Given this list of marker genes Mtor, Chrnb2, Atp1a3, Npas4, Rptor, Ext1, Htt (NCBI Gene Id 319350), Atxn1, Chd8, Il1b, Dlg4, Brinp1, Tsc2, Ankrd11, Pianp, Nlgn2, En1, Bpifa1, Grpr, Drd1, Gad1, Nlgn4l, Grin1, Grid1, Septin5, Cln8, Cic, Vps13a, Oxtr, Gabrb3, Avpr1a, Shank2, Pcm1, Nfix, Cx3cr1, Ltf, Bpifa5, Brinp3, Kalrn, Dvl1, Dscam, Gng8, Ulk4, Cntnap2, Cc2d1a, Mapk8ip2, Nrxn3, Vps13b, Kcnq2, Shank3, Gnb1l, Bbs4, Th, Mecp2, Nr2e1, Tbx1, Atxn1l, Taar5, Pten, Grp, Mkks, Ptchd1, Negr1, Trem2, Shank1, Nlgn3, Efr3b, Oprm1, Fmr1, Nrxn1, Ucn, Kcnq1, Avp, Nrxn2, Oxt, Eif4ebp2, Garem2, here is a description of the gene set: studied in species Mus musculus Mouse Gene Set: GOBP_BIOLOGICAL_PROCESS_INVOLVED_IN_INTRASPECIES_INTERACTION_BETWEEN_ORGANISMS Any process in which an organism has an effect on an organism of the same species.